The following is a description of a gene set: Genes predicted to be targets of miRBase v22 microRNA hsa-miR-5685 in miRDB v6.0 with MirTarget v4 prediction scores > 80 (high confidence targets). studied in species Homo sapiens from publication Chen Y, Wang X (PMID 31504780) Human Gene Set: MIR5685, and this is the list of marker genes: TMEM127, INKA2, GPBP1, HNRNPR, OCLN, CNR1, HABP4, CPT1A, ITPRIPL2, FAM76A, PLEKHA3, ARHGAP21, ADSS2, TBC1D8B, LYSMD1, STAC2, C9orf72, KCND1, PHF21A, FAM217B, PCDH7, DDX6, TRIQK, STAG2, GINS2, MARCHF1, ZNF330, SUFU, ATP8B1, SGPP2, NAA50, KDM6A, CERT1, LRRC4, CFL1, KSR2, N4BP3, STK32B, KDM3B, ALG13, TESK1, MMD, UBE2D4, ASB1, ZDHHC8, EMILIN2, INPP5A, VWA8, GRIPAP1, TREML2, KIAA1549, KRBOX5, STRBP, GPRASP3, WFDC2 (NCBI Gene Id 128489), CNTNAP2, RAB31, BCAP29, TNRC6A, INHBB, GALNT15, EVC, GRB2, ZDHHC18, MMP14, RIMS3, MZT1 (mitotic spindle organizing protein 1, NCBI Gene Id 440145), ADCYAP1R1, NMT1, VAMP3